The following is a description of a gene set: An abnormality of the thoracic vertebral column. studied in species Homo sapiens Abnormal thoracic spine morphology Human Gene Set: HP_ABNORMAL_THORACIC_SPINE_MORPHOLOGY, and this is the list of marker genes: DMD, RYR1 (ryanodine receptor 1), PCGF2, RAPSN, ADGRG6, SC5D, KIF22, NKX3-2, CYP27A1, MGAT2, RMRP, NARS1, SPRTN, HINT1, ERCC2, GBA1, RNF113A, SMARCAL1, XYLT2, SCN4A, DES, VPS33A, RBBP8, LMNA, PEX5, IARS2, AK9, AP1G1, FLI1, FLNB, GTF2H5, PLOD1, GTF2E2, COL13A1, BAG3, TUBB3, EXTL3, ERLIN1, CHRNA1, COL2A1, SLC26A2, DYM, TONSL, GDF3, RAB3GAP2, CDH11, KMT2D, TBX5, ADAMTS15, ZFX, FBXO28, AGRN, TRAPPC2, KY, NPR2, TARS1, GNS, NEPRO, ANKRD11, LBR, CCN6, AARS1 (NCBI Gene Id 16), AMER1, NFIX, MAN2B1, RAB5IF, GLB1, MOGS, MYPN, ACTA1, MED12L, GUSB, SGCA (NCBI Gene Id 6442), MYH7, PLK4, ALDH3A2, CHRND, TPM2, PIK3C2A, LRP4, SRD5A3, CHRNE, SOX9, PHF8, TRPV4, ALMS1, CARS1, PUF60, SOX5, POP1, CHRNB1, COG1, MTRFR, TPM3, HECTD4 (HECT domain E3 ubiquitin protein ligase 4), NEK9, ITCH, SERPINH1, VPS13B, PRKG2, PYCR2, AEBP1, PIK3R2, FGFR3 (fibroblast growth factor receptor 3), AIFM1, DOK7, MUSK, WDR81, KDM6A, ZMPSTE24, ERCC3, GNPTAB, LHX3, MPLKIP (NCBI Gene Id 136647)